The following is a description of a gene set: Human Gene Set: MODULE_203 Genes in the cancer module 203. species: Homo sapiens, and this is the list of marker genes: H2AC6, H2AC8, H2AC18, CENPA, CHAF1B, H2AZ1, H1-1 (H1.1 linker histone, cluster member), H2BC21, RBMXL2, H2BC11, H1-6, H1-2, H2AX (NCBI Gene Id 3014), H2BC12, H1-0, H2BC13